The following is a description of a gene set: Genes predicted to be targets of miRBase v22 microRNA hsa-miR-4671-3p in miRDB v6.0 with MirTarget v4 prediction scores > 80 (high confidence targets). Human Gene Set: MIR4671_3P species: Homo sapiens from publication Chen Y, Wang X (PMID 31504780), and this is the list of marker genes: CCNY, CLIP1, MYBL1, LMLN, AGO4, LY75, RAB5A, KCNA4, HS3ST5, SBF2, CCDC126, POU4F1, ACVR1, THSD7A, PSTPIP2, ZFAT (zinc finger and AT-hook domain containing), SPRED1, ZNF449, DOCK3, STT3B, TLCD3A, RBM25, ACSL1, CEP170, ACBD5, ENPP5, ST18, NPNT, FERMT2, CLCN5, CYP2U1, CRACD, GPBP1, GAREM1, DGKE, EPN2, PNRC1, RFX7, IRF1, NECTIN3, MTMR10, SLMAP, ZNRF3, ZNF213, TOB1, SPHK2, SPOCK1, MLLT6, TMOD1, IMPDH1, RND2, ZBTB4, THOP1, OTUD3, RBM17, FOSL1, JADE1, LRP8, PIK3CB, ZBTB20, MAF, KBTBD8, FRZB, UBE3B, USP8, FAT3, PTPRG, WNK1, NIPA2, SERINC3, CPEB2, NPAT, CCND3, HCFC2, RTCA, ZMAT3, SECISBP2L, USP13, LRP12, ZNF451, CHST1, ABRAXAS2, LDAH, SLC2A4RG, DPP8, PSAP, DLC1, PPARG, ACBD3, ITGB8, SRSF11, C2orf15, WNT2B, OLFM3, MDM4, SRSF2, MB21D2, QSER1, ANKRD52 (NCBI Gene Id 283373), MET, CLCN3, DCUN1D3, SETD7, AKAP11, FAM98A, PRR32, ZHX1, RAP1A (RAP1A, member of RAS oncogene family), KLF7, STX7 (NCBI Gene Id 8417), TRAM1, SYBU, TOGARAM1, DNAAF6, DIAPH3, STIM2, PRKAA2, LGALSL, ARHGEF26, IGSF3, CNOT6L, CMYA5, PPFIA2, SH3D19, PELI1, UBE2D2, RALGPS2, SPATA2, ZNF3, FMR1, SLC10A3, JMY, CSMD1, MAPK6, APPL1, UNC13A, KMT2C, PCNX1, ARHGEF4, NACC2, HIVEP2, WDFY3, ULK2, CPPED1, MPHOSPH9, RHOH, NR3C2, RUNX3, IKZF5, EPC1, RAB30, DSEL, PIK3R5, ARFGEF1, PLLP, UBB (NCBI Gene Id 91253), BAHD1, HOOK3 (NCBI Gene Id 84376), TTYH1 (NCBI Gene Id 57348), DDX6, VGLL4, SPART, NFIA (NCBI Gene Id 4774), AFF3, ERP44, RAB12, MARK3, SDR42E1, TSHZ1, CCDC146, KCNJ10, TMEM250, TGFBR1, GJA1, KRTAP26-1, PURG, TRIB1, TACC2, BPTF, SOCS5, TBL1XR1, TES, KLF3, AR, CDK19, SLC6A6, CPEB1, FAM135A, KRTAP22-2, TRPM1, MYO10, PAN3, TANC2, SLC44A1, FUT9, HPRT1, EBF3, CAPRIN2, MDFIC, EDA, SNX2, IGF1, ZIC5 (NCBI Gene Id 85416), VPS13D, PIP4P2, SHANK2, ING2, PHAF1, PAFAH1B1, SPESP1, SLAIN1, PDIK1L, TOB2, DHX8